The following is a description of a gene set: Reactome Pathway: FGFR2 alternative splicing part of: Signaling by FGFR2 This event has been computationally inferred from an event that has been demonstrated in another species.<p>The inference is based on the homology mapping from PANTHER. Briefly, reactions for which all involved PhysicalEntities (in input, output and catalyst) have a mapped orthologue/paralogue (for complexes at least 75% of components must have a mapping) are inferred to the other species. electronically inferred by orthology from the curated human pathway studied in species Mus musculus, and this is the list of marker genes: Polr2f, Polr2c, Polr2b, Polr2k, Polr2e, Ptbp1, Gtf2f1, Polr2a, Polr2i, Gtf2f2, Polr2l